The following is a description of a gene set: The chemical reactions and pathways resulting in the formation of UDP-N-acetylglucosamine, a substance composed of N-acetylglucosamine, a common structural unit of oligosaccharides, in glycosidic linkage with uridine diphosphate. Mouse Gene Set: GOBP_UDP_N_ACETYLGLUCOSAMINE_BIOSYNTHETIC_PROCESS species: Mus musculus, and this is the list of marker genes: Uap1l1, Gnpda1, Gfpt1, Amdhd2 (NCBI Gene Id 245847), Gnpda2, Pgm3, Gfpt2, Uap1, Gnpnat1 (glucosamine-phosphate N-acetyltransferase 1)